Given this list of marker genes Cntnap1, Ugt8a, Nfasc (neurofascin), Mal, Epb41l3, here is a description of the gene set: species: Mus musculus Mouse Gene Set: GOBP_PROTEIN_LOCALIZATION_TO_PARANODE_REGION_OF_AXON A cellular protein localization process in which a protein is transported to, or maintained at, the paranode region of an axon.